The following is a description of a gene set: Genes containing one or more binding sites for (ZNF560) in their promoter regions (TSS -1000,+100 bp) as identified by GTRD version 20.06 ChIP-seq harmonization. studied in species Homo sapiens from publication Yevshin I, Sharipov R, Kolmykov S, Kondrakhin Y, Kolpakov F (PMID 30445619) Human Gene Set: ZNF560_TARGET_GENES, and this is the list of marker genes: SPEG, MED21, MKLN1, PDE4C, LAMP3, FES (FES proto-oncogene, tyrosine kinase), TRIM67, LHFPL3, ADA, RNF130, ANGPTL6, HMGA1, KAT8, IQCH, LTBP2, OSBPL1A, LINC-PINT, MTO1, TRIM15, EXOSC2, SIX5 (NCBI Gene Id 1754), CACNG2-DT, TTC1, NCKAP1L, SYCE2, SNHG30, ENSG00000244137, NOL6, HAPLN2, ALDOA, CWC25, CAPN2 (NCBI Gene Id 824), PITPNC1, PHPT1, SSBP3P1, CCDC144BP, NAA16, SH2B2, MEMO1P4, CACNG2, RRN3P1 (RRN3 pseudogene 1), AAGAB, NLE1, TIGD7, GOLGA3, GPR6 (G protein-coupled receptor 6), WNT8A, PGRMC1, OLFM2, RND1, COPB1 (NCBI Gene Id 51664), CROCCP3 (CROCC pseudogene 3)